The following is a description of a gene set: Monocyte-derived dendritic cells (DC) and macrophages (MΦ) generated in vitro from the same individual blood donors were exposed to five different pathogens, and gene expression profiles were assessed by microarray analysis. Responses to Mycobacterium tuberculosis and to phylogenetically distinct protozoan (Leishmania major, L. donovani, Toxoplasma gondii) and helminth (Brugia malayi) parasites were examined, each of which produces chronic infections in humans yet vary considerably in the nature of the immune responses they trigger. from publication Chaussabel D, Semnani RT, McDowell MA, Sacks D, Sher A, Nutman TB (PMID 12663451) species: Homo sapiens Human Gene Set: GSE360_CTRL_VS_B_MALAYI_HIGH_DOSE_DC_DN Genes down-regulated in comparison of dendritic cells (DC) versus DCs exposed to B. malayi (50 worms/well)., and this is the list of marker genes: SPON1, HMBS, GNB5, CILK1, MAX, CCL23, HSPA5, PPBP, TUBB2A, ZRSR2 (NCBI Gene Id 8233), ZSCAN12 (zinc finger and SCAN domain containing 12), DPM2, ZNF280B, CRH, ACTC1, TFF3, ILF3, MUC6, PHKG1, GUSBP11, DAPK1, SLC7A5, NTRK1, NCF4, CHD1L, RCN2, OVOL3, CUL9, RAB3GAP1, QDPR, GNG4, KXD1, SHOX2, SERPINB3, SLC35A3, IPO7, MSLN, AURKB, APOA4, HBBP1, TKT, SYMPK, INPP5E, DDX52, ADAM28, TTLL4, PTGES3, GPC1, COX7A1, GUCY2F, TLR6, PLA2G15, STRN (NCBI Gene Id 6801), BMP2, DEFB1, ZNF136, IRS2, CDS1, FCAR, DLEC1, MMP14, XCL1, ENDOU, UGCG, C1QBP, SEMG2, GPX7, HAGH, HMCES, PDE6D, APOD, LRP2, IL1RL2, TRIM27, CROT, KDM7A, ME3, ARR3, PHB2, FRAT2, CSF3, EIF1AX, EPHX2, IFI6, PRKY (NCBI Gene Id 5616), SPINK4, ATXN10, P2RX7, USP20, ABCB4, PDE1A, AMPD3, DAGLA, MPZL1, XPC, FGFR4, AP4E1, CEACAM7, SPRY2, ARHGAP32, SULF1, ARL4A, PPP4C, GPR35, ZNF92, NPFF, OSTF1, LTBP1, CYTH3, GH1, MAPK1, ING3, NAE1, PHLDA2, MBNL2, MAG, PLAT, NAPA, TUBB7P, PDK2, ELAVL3, FHL1, CEP68, H2AC16, UBE2K, PTPRCAP, CAPRIN1, CTF1, SCAMP3, TMEFF1, RALA, SCN1B, AASS, MICAL3, PYGM, GNA11, PADI2 (peptidyl arginine deiminase 2), RUNX1, MAGEA11, RUVBL1 (RuvB like AAA ATPase 1), GNRH2, FOXN3, AMHR2, IMP4, HTR2C, ERCC8 (NCBI Gene Id 2075, ERCC excision repair 8, CSA ubiquitin ligase complex subunit), RAB9A, CABP1, PHF2, ROR2, RAB40A, CD40, SIRPB1, HLA-G, PHGDH, SUCLG2, MFAP3, NACC2, SLC16A5, UBL4A, ZZEF1, FCGR1A, PLCE1, SLIT2, IRF8, TAF1B, ERI2, STMN2, TAX1BP3, PDCD6, CLCA2, HSPA1A, CEP104, PBX2 (PBX homeobox 2), TSC22D1, EZH2, WWP2, PHB1, RNF44, HNRNPAB, CDKN2A (NCBI Gene Id 1029), TBCB, COL1A2, SYN1, RHOQ, VEZF1, SMARCC2 (NCBI Gene Id 6601), C2CD2, ETS2, UBE2S, BTBD8, IQSEC2, PRPF40A, OSM, INPP4B, CUBN, CLEC16A, SCARF1, CD93